Given this list of marker genes KDM4A, KDM4E, KDM4C (lysine demethylase 4C, NCBI Gene Id 23081), KDM4D, KDM4B, here is a description of the gene set: Catalysis of the removal of a methyl group from a tri or a dimethyl-lysine residue at position 9 of the histone H3 protein. This is a dioxygenase reaction that is dependent on Fe(II) and 2-oxoglutarate. studied in species Homo sapiens Human Gene Set: GOMF_HISTONE_H3K9ME2_H3K9ME3_DEMETHYLASE_ACTIVITY